The following is a description of a gene set: from publication Victora GD, Dominguez-Sola D, Holmes AB, Deroubaix S, Dalla-Favera R, Nussenzweig MC (PMID 22740445) species: Homo sapiens Microarrays of gene expression in human germinal center light zone and dark zone B cells sorted according to the expression of cell surface molecules CD83 and CXCR4 We used microarray data to identify genes differentially expressed by B cells in the light and dark zones of germinal centers from human tonsil specimens. Human Gene Set: GSE38697_LIGHT_ZONE_VS_DARK_ZONE_BCELL_UP Genes up-regulated in B lymphocytes: light zone versus dark zone., and this is the list of marker genes: LIN9, MRPS31, MED15 (NCBI Gene Id 51586), TELO2, EIF4G2, NDST3, ABHD12B, KGD4, GSTO1, ENOX2, AIM2, OCRL, PSMG2, AGXT, MFSD14A, NUBPL, COX16, SOCS6, SEC16A, BCL10, NUDT2, PHKB, STK39, LZTFL1, GSK3B, TSNAX, FASTK, PAXBP1, MOB1B, TMEM184C, CD226, DPY19L1, ARHGEF2, ATXN1, ABRA, CD69, KLHDC3, NFATC1, MTFR1, RIPK1, SLC25A46 (solute carrier family 25 member 46), MGP, CEP85, B3GNT2, GNG2, IFI16, SCLT1, THY1, RABGAP1L, CD80, TLR1, CCDC141, ST8SIA4, SELENOK, ALG13, NAA35 (NCBI Gene Id 79688), DNAJB9, ACTR10, SEPTIN8, FUNDC1, AP3S1, CCDC116, WHAMM, NFIX, SDCCAG8, E2F5, PKN1, ASNSD1, GPR15, AUH, BTD, ENTR1, DAPK2, NPAT, RNPEPL1, AP1S2, FAM234A, PTCH1 (NCBI Gene Id 8015), TWF2, DYNC1I2, H2BC4, CTDSPL2, CDKL5, COX17, RAB10, PMPCB, PON2, OSGIN2, MED6, FOCAD, TBC1D5, TBCCD1, TIAL1, AGA, MRPS15, CCDC163, GAMT, GTF2E2, DST, DHX33 (DEAH-box helicase 33), CD200R1, LPP, STAMBP, CD24, LIAS, GSAP, KLF13, SGMS1, POLR2I, NMNAT1, MPHOSPH10, CATSPER2, CALHM2, ZDHHC15 (NCBI Gene Id 158866), CARHSP1, RPP14, LRWD1, IPPK, ARHGAP27, TOX4, VPS45, AP1S3, MAGI3, CR1L, C1D, TEC, GALNT12, ZSCAN12, PKNOX1 (PBX/knotted 1 homeobox 1), DDHD2, NKAP, SRSF6, BYSL, LXN, HEG1, TAB2, SPATS1, RSPH9, TMEM154, UBASH3B, RAD9B, ANAPC10, LRRC27 (NCBI Gene Id 92295), RCOR3, NUSAP1 (nucleolar and spindle associated protein 1), ATP8B4, NSMAF, TRMT11 (tRNA methyltransferase 11 homolog), CEACAM1, PPP2R2A, TBC1D8B, RIOK1, H3-3B, MRPL45, MPRIP, CEP83, SLC25A21, APBB1IP, SLC35A3, GDAP2, ZC3H8, RBM27, SLC37A3, FAR1, RTTN, CYB5R1, EGR2, SLAMF6, CCDC38, TFPI, DHRS7, KLHL2, APEX2, CD48